The following is a description of a gene set: Human Gene Set: HP_INTELLECTUAL_DISABILITY_MODERATE species: Homo sapiens Moderate mental retardation is defined as an intelligence quotient (IQ) in the range of 35-49. Intellectual disability, moderate, and this is the list of marker genes: RPGRIP1L, NSUN2, FBLN1, ITPR1, KDM5B, ENTPD1, COL1A2, HYCC1, FZR1, PREPL, FAT4, DNMT3A, SCN1A, CLCN4, APC2, VPS16, PIGL, IL1RAPL1, AKT1, TAF4, SMARCB1, OPHN1, NFIX, SLC9A7, PSPH, CASK, DCHS1, HPRT1, PTRH2, EGF, PPM1B, ZFX, MYT1L, CC2D2A, PIGV, CNTNAP2, ATP6V0C, SNRPN, RTTN, SMARCA4, SLC16A2, PLP1, SOX4, AGO1, TOR1A, RNU4-2, ARID1A, NSD1, PAX1, SLC35A3, ARID2, MAN1B1, PGM3, MED25, EXT2, TAF1, SOX11, PDE2A, KLF13, PTDSS1, PRMT7, CAMKMT, PGAP2, MECP2, KIF5A, SRCAP, AHDC1, DHX9, CWF19L1, TMEM70, PCDH19, PUF60, GRIN1, FMR1, GRIN2A, PIGA, CPLX1, TBCD, MED13L, YY1, PGAP1, ASXL3, TTI2, CDK5RAP2, UBE2A, NCAPH, FGFR3, CHD8, ZBTB11, UROC1, LAMA1, XYLT1, SATB2, ARID1B (AT-rich interaction domain 1B), STAG2 (NCBI Gene Id 10735), ANK3, GLUD1, GRIA3, NDUFAF1, WBP4, AFG2A, COQ8A (NCBI Gene Id 56997), DPAGT1, SMARCE1, SARS1, MAGEL2, INPP5E, MPV17, SMARCC2, AP1S2, KANSL1, NCAPD2, SYNGAP1, ALX4, PIGW, SLC45A1, WDR62, ZNF711, NHS, DPF2, PIGO, POLR3B, CENPJ (NCBI Gene Id 55835), ZMYM3 (zinc finger MYM-type containing 3), SMARCD1, THOC2, TMEM67, GTF2E2, HNRNPK, PRPS1, NDUFAF5, PIGY, ARX, TDO2, PGAP3, APC, FGFR2, SLC3A1, FOXP1, SHMT2, DMXL2, SMOC1, COG5, RBMX, HNRNPC, WARS2, POLR3A, RSPRY1, NDN, CACNG2, TWIST1, COQ4, ANKRD11, RNU4ATAC, TGM6 (NCBI Gene Id 343641), PPP2R5D, CHRNA7, ADCY5, COG1, SRPK3, MAB21L1, TBC1D24, ALDH18A1, CCNK, RDH11, CDH11, MED12, OCA2, EBP, L1CAM, MAB21L2, SHANK3, USP9X, MT-TE, HMGCL, CWC27, CUL4B, FTSJ1, TCF4